The following is a description of a gene set: Human Gene Set: LINDGREN_BLADDER_CANCER_CLUSTER_2A_UP from publication Lindgren D, Liedberg F, Andersson A, Chebil G, Gudjonsson S, Borg A, Månsson W, Fioretos T, Höglund M (PMID 16532037) Genes whose expression profile is specific to Cluster IIa of urothelial cell carcinoma (UCC) tumors. species: Homo sapiens We used gene expression profiling, mutation analyses of FGFR3 and TP53, and LOH analyses of chromosome 9 and the TP53 region on chromosome arm 17p, to molecularly characterize 75 Ta and T1 bladder carcinomas. We identified four major cellular processes related to cell cycle, protein synthesis, immune response, and extra cellular components that contribute to the expressional heterogeneity of early-stage urothelial cell carcinoma (UCC). Activating FGFR3 mutations were found at the highest frequency in G1 tumors (80%), and showed a strong correlation with FGFR3 expression. In contrast, G3 tumors displayed mutations in less than 10% of the cases and a low level of FGFR3 expression. Even though LOH on chromosome 9 was not associated with any specific expression pattern, our data indicate that loss of chromosome 9 is associated with tumor development rather than initiation. The combined analyses suggest the existence of two types of UCC tumors, one which is characterized by FGFR3 mutation or expression, high expression of protein synthesis genes, and low expression of cell cycle genes. Furthermore, the presented data underscore FGFR3 receptor involvement in urothelial cell transformation as the presence of FGFR3 mutations has a major impact on the global gene expression profile of bladder carcinomas., and this is the list of marker genes: DGKQ, LAD1, ADRB1, DDO, S100A4, SNCG, ABL1, RAB25